The following is a description of a gene set: studied in species Mus musculus Human Gene Set: IWANAGA_CARCINOGENESIS_BY_KRAS_PTEN_DN Cluster 2: genes down-regulated in lung tissue samples from mice with oncogenic form of KRAS and inactivated PTEN. Phosphatase and tensin homologue deleted from chromosome 10 (Pten) is expressed aberrantly in non-small cell lung cancer cells, but the role of Pten in lung neoplasia has not been fully elucidated. In this study, we used a genetic approach to inactivate Pten in the bronchial epithelium of mice. Although, by itself, Pten inactivation had no discernible effect on bronchial epithelial histology, it accelerated lung tumorigenesis initiated by oncogenic K-ras, causing more rapid lethality than that induced by oncogenic K-ras alone (8 weeks versus 24 weeks of median duration of survival, respectively). Lung tumors arose in K-ras mutant, Pten-deficient mice that rapidly obstructed bronchial lumina and replaced alveolar spaces. Relative to K-ras mutant tumors, the K-ras mutant, Pten-deficient tumors exhibited more advanced histologic severity and more prominent inflammation and vascularity. Thus, Pten inactivation cooperated with oncogenic K-ras in promoting lung tumorigenesis. from publication Iwanaga K, Yang Y, Raso MG, Ma L, Hanna AE, Thilaganathan N, Moghaddam S, Evans CM, Li H, Cai WW, Sato M, Minna JD, Wu H, Creighton CJ, Demayo FJ, Wistuba II, Kurie JM (PMID 18281487), and this is the list of marker genes: GPR107, C17orf58, ARHGAP25, GPR153, GSN, ARHGEF4, CYP4A11, CETN1 (NCBI Gene Id 1068), OPRK1, PLCG1, SERPINB6, CCDC134, SERPING1, SNTB2, SMG9, SCAF4, XPR1, MTOR, MRPL54, OGN, ABCB1, VPS39, MMP12, SSH2, SPART, ADRB1, DPT, RCN1, LGALSL, CRISP3, SPATS2L, SLC29A2, DDN, PTPRD, CACNA1A, WASF2, SV2B, INMT, GREM1, OSBP, SLC16A5, HIP1, PSPC1, CAV2, HOXB4 (homeobox B4), SPARCL1, ADCY8, HS3ST3B1, FOXK2, CD93, TCERG1, HBP1 (NCBI Gene Id 26959), NDN, HLA-DQB1, EARS2 (glutamyl-tRNA synthetase 2, mitochondrial), ITPR2, RSL24D1 (ribosomal L24 domain containing 1), TGM2, NCALD, DDX50, HEBP2, CBR3, ZCCHC14, NID1, PPP2R5B, KITLG, SYNM, ACTC1, PTPRC, IRGQ, IRX1, SELL, HNRNPF, NDUFB10, SIK2, PAPPA2, MUC15, SRD5A2, EDC3, ASCL3, TMEM174, DCLK1, FDX2, PDLIM3, CEMIP, CPNE8, TCF21, EFNB2, ANGPTL2, FOXH1, NDUFV3, ICOS, GPR182, KRT80, SET, SNAI3, VPS50, CLDN5, JUN, GPD2, CD28, STON2, SHFL, MAP4, ITGB3BP, DAAM1, TNPO1, ENDOG, AJM1, CYCS, PDILT, TRA2A, DDHD2, PMP22 (peripheral myelin protein 22), PRP4K, CABP2, TTLL8, ZZEF1, XPA, RGS2, CHRNA9, CORO1A, AMIGO1, YOD1, LRP8, PKD2, AKAP12, B3GNT6, EID2, KATNBL1 (katanin regulatory subunit B1 like 1), CYTH3, KLF6, GREM2, TRNAU1AP, ZNF595, CNN1, CCND3, GPAT4, GNB4, FA2H, KLF7, EEF1AKMT1, MCAM, PLTP, MFSD13B, INTS2, SOX7, CHSY1, CCDC81, THOC7, ST6GALNAC3, CDT1, SLC39A10, PTPRK (NCBI Gene Id 5796), SATB1, ZEB1, TGFB1I1, PDZD9, GLIS2, CTDSPL2 (NCBI Gene Id 51496), TPM1, H1-9P, YPEL3, EBF1, HNRNPU, PHEX, SPTBN1, PLOD2, KLF4, MYT1, SWSAP1, MAP2, MS4A6A, FBXW12, FZD4, ZNF672, GLP1R, CAVIN2, ZSWIM8, METTL6, OXCT1, MIDEAS, AUH, TEK, TLX1, PPBP, GIMAP6, ADH1A, RAMP2, ARHGEF2 (NCBI Gene Id 9181), FGF14, FAM229B, FAM9C, FOXF2, SMARCD2, RSF1, PICALM, KCNG4, IRS4, CNR2, NEK11, CCDC174 (NCBI Gene Id 51244), CIR1, LDB2, SNX21, PEA15, TSPAN13 (tetraspanin 13), ADGRL2, PLXDC2, IPPK, LRRC72, GTF2I, ARID4B, TMEM87B, ZNF839, RGMB, ATP10D, DEPP1, ADAM1A, PROSER2, FBXL7, PDZD2 (PDZ domain containing 2), SHISA6, ABHD17C, ADGRE5, MARCKS, TNNT2, OR5B3, OTUD3, RHOJ, NSF, SREK1, BRCA1, RASSF6, TAX1BP1, TMEM184B, PDE4DIP, DYRK1A, IFIT2, CXCL13, CUL3, CLEC14A, SUGP1, MAP7, B3GALNT2, SEMA3E, PPP1R14A, GZMA, SLC22A3, KLK7, TMEM263, MEIS2, MPDZ, INTS9, PRSS59P, METTL17, ST18, CLEC2L, MYT1L, CFHR4, EIF4G2, ANKRD34A, PAQR5, BGN, HOXB5, NXN, FHL1, FMO1 (NCBI Gene Id 2326), ENPP2, SUGP2, TBC1D24, CCNJL, PSEN1, ZBTB44, TTC21B, ARHGAP18, CACNG2, CHCT1, CRIPT, STPG4, HELZ, TTC6, TBP (NCBI Gene Id 6908), DDX27, ADGRL4, TMEM170A, CDON (cell adhesion associated, oncogene regulated), NDST3, IRF8, ZSCAN4, RPP40, AK4 (adenylate kinase 4), ELF4, SUSD4, CHIC2, CLCA4, VCL, GEMIN8, PLVAP, WWOX, DPF1, ABTB2, SMCHD1, GEN1, IL2RG, CFAP91, COL4A1, PRDM1, MYO5A, RICTOR, HAUS3, HOXA3, ZMAT4, TXNL1, GALNT13, ANKRA2, CELF6, ZFHX4, ENG, ATP13A4 (ATPase 13A4), PPP1R14B, GAS1, PAXIP1, GTPBP3, TTL, PFKFB3, LIG3, MAN1B1, TTC28, AMZ1, TMED5, VPS51, BTBD6, UTP14A, INSR, SYN2, C7orf57, ERF, HK1, RASGRP2, MAST3, CBFA2T3, GRM5, ABCD2, MMP2, CLIP1, MBLAC1, ABCB6, SCFD2, IQGAP3, CALCRL, ALDH1A1, CTIF, TMTC1, DCP2, ZBTB14